Given this list of marker genes FSTL3, FST, DAND5, SMAD7, NOMO1, CER1, FKBP1A, SMURF1, NOMO3, DACT2, ACVR1, IGSF1, MAGI2, FKBP1C, LEMD3, SMAD6, NCLN, SKI, here is a description of the gene set: Human Gene Set: GOBP_NEGATIVE_REGULATION_OF_ACTIVIN_RECEPTOR_SIGNALING_PATHWAY studied in species Homo sapiens Any process that stops, prevents, or reduces the frequency, rate or extent of the activity of any activin receptor signaling pathway.